The following is a description of a gene set: The chemical reactions and pathways resulting in the formation of carbohydrates, any of a group of organic compounds based of the general formula Cx(H2O)y. Human Gene Set: GOBP_CARBOHYDRATE_BIOSYNTHETIC_PROCESS studied in species Homo sapiens, and this is the list of marker genes: ST3GAL4, LALBA (NCBI Gene Id 3906), SELENOS, PARP1 (NCBI Gene Id 142), SLC37A4, PCK1, PTH, B3GALT5, INSR, PRKAG3, LEP, ST3GAL2, AKT2, PGM1 (phosphoglucomutase 1), ST3GAL3, CHST12, PPP1R3G, ENO2, FOXO1, SNCA, GSK3B, PDK2, G6PC1, SORD, AKT1, MIR15B, PDGFB, GCK (NCBI Gene Id 2645), FUT3, NHLRC1, GPD2, ENPP1, DGAT2, DDB1, FUT2, DGKQ, LHCGR, HAS1, P2RY6, PER2, SDHAF3, SMPD3, GPD1, FUT1, PASK, OGT, FUT5, CHST15, EP300, ST6GALNAC6, MIR107, PFKFB1 (NCBI Gene Id 5207), CRY1 (cryptochrome circadian regulator 1), PGD, ADIPOQ, B3GALT2, PRKAG2, AGL, RBP4, TGFB1, CHST10, IGF1, CHST8, HAS2, TPI1, SLC39A14, CHST11, GPI, ERFE, HAS3, G6PC2, PGAM1, PRKACA, MTCL2, EXT2, NR3C1, SIK1, ARPP19, PPP1R3D, ATF4, GNMT, AKR1B1, SLC25A11, PTPN2, EPM2A, ST3GAL6, C1QTNF3, PGM2, P2RY1, SDS, GYS1, PPP1R3E, MIR103A1, ST8SIA6, ACADM, PPP1R3C (NCBI Gene Id 5507), FBP1, MPDU1, PCK2, SIRT6, PRKAG1, FUT7, PRKG1, MIR195, INPP5K, ADCYAP1R1, FUT8, SLC25A10, GSK3A, INS, GBE1, C1QTNF12, SORBS1, CHST14, CRTC2, FBP2, ST6GALNAC1, EGF, SIRT1, GYG2 (NCBI Gene Id 8908), DYRK2, KAT2B, WDR5, NNMT, GYS2, B3GALT1, FUT4, PPARA, NANS, NDST1, AP2A1, NLN, B4GALNT2, ALDOB, SIRT7, FUT6, USP7, MIR1271, PPARGC1A, ALDOC, GYG1, PGK2, B3GALNT1, PPP1R3B, TCF7L2, EPM2AIP1, LEPR, PPP1CA, GPER1, NFKB1, RANBP2, IGF2, CLK2, B4GALT1, G6PD, ZNF692, PPP4R3A, PPP1R3A, CD244, B3GAT2, SESN2, GOT1, PLEK, AVPR1B, MST1, SERPINA12, ENO3, EXT1, PGP, NTSR1, B3GALT4, SLC25A13, GCG, PPP4R3B, MDH2, IRS2, UGP2, CHST9, CHST13, KAT2A, CLTC, PC, NR0B1, NR1D1, ENO1, PTH1R, FUT9, PPP1R3F, MGAT2, GRB10, IRS1, G6PC3, SLC35B4, PGK1, PGAM2, ATF3, FUT10, ST6GALNAC5